Given this list of marker genes Ppic, Ptpa, Fkbp1b, Fkbp14, Fkbp2, Ppid, Ppie, Ppif, Pin1, Fkbp9, Ppig, Ppia, Fkbp11, Ppil1, Pin4, Ppwd1, Ppil4, Fkbp7, Fkbp5, Nktr, Fkbp4, Fkbp10 (FK506 binding protein 10), Fkbp3 (FK506 binding protein 3), Fkbp1a, Ppih, Fkbp8, Ppib, Ppil3, here is a description of the gene set: Catalysis of the reaction: RNA polymerase II large subunit CTD heptapeptide repeat (consensus YSPTSPS) cis-proline (omega=180) = RNA polymerase II large subunit trans-proline (omega=0). studied in species Mus musculus Mouse Gene Set: GOMF_RNA_POLYMERASE_II_CTD_HEPTAPEPTIDE_REPEAT_PEPTIDYL_PROLYL_ISOMERASE_ACTIVITY